Given this list of marker genes ECEL1, GTF2IRD2, SCN1A, ITGA7, TTN, PCYT1A, SPRTN, DKK1, PIGY, COL1A1, HSPG2, TFAP2A, HACD1, PSTPIP1, ERI1, SCUBE3, COMP, EIF4H (eukaryotic translation initiation factor 4H), LGI4, PPP1R12A, SCO2, FBXO28, GNPNAT1, WRN, KRT1, MYH3, IRF6, MVK, ERCC1, DDR2, ALOXE3 (arachidonate epidermal lipoxygenase 3), HFE, LMNA, GLB1, ACVR1, SCYL2, HRAS, MFN2, MASP1, COL25A1 (NCBI Gene Id 84570), LAMB2, WNT7A, ERCC8 (NCBI Gene Id 2075), SF3B4, MMP23B, SGSH, BAZ1B, SHH, LSS, FKBP10, ADGRG6, ACTA1, GABRG2, PRG4, TGDS, LBR, SMARCB1, TAF6, COL6A1, ADAMTSL2, PIEZO2, KCNAB2, PITX1, PCDH19, TBX4, GTF2I, SCN4A, GPC6, L1CAM, SCN9A, SCN1B, ALOX12B, CNTNAP1, RAD21, POMT1, BHLHA9, CAPN3, MMP13 (NCBI Gene Id 4322), MAF, SCARF2, RECQL4, NALCN, ERGIC1, ITCH, SLC22A4, TYROBP, PLOD1, UBA1, ELN, TREM2, VCP, MECP2, ALDH3A2, ALDH18A1, FGF9, PAX3, HOXA11, SFRP4, ESCO2, CHMP1A, STXBP1, KIF22, MET (MET proto-oncogene, receptor tyrosine kinase), COL1A2, NEK9, PYCR1, NFIX, NPR2, STAT4, ASXL1, GABRD, BANF1, B3GAT3, HGSNAT, MAN2B1, CCN6, IL10, RAB3GAP1, ACTB (NCBI Gene Id 60), RSPRY1 (ring finger and SPRY domain containing 1), GNS, SCN2A, FGFR2, SPRED2, GNB2, TRAPPC2 (trafficking protein particle complex subunit 2), FLNC, AGA (NCBI Gene Id 175), EMD, HCN1, CKAP2L, GPHN, SKI, TNFRSF11B, EMG1, LTBP2, TNNI2, TONSL, FGFR1, BMP6, SHOX, COL2A1, FILIP1, VAPB, TGFB1, IDUA, BMPR1B, HPGD, ZC4H2, PNKD, STAG1, GTF2IRD1, VANGL1, ANTXR2, EPG5, ADAMTSL4, DEAF1, MAP3K7, ARSB, PDPN, PSMB8, FGFR3, JAG2 (jagged canonical Notch ligand 2), CBS, INPPL1, GJB2, SYT2, GUSB, FUZ, ERCC2, ABCC9, FHL1, KCNK9 (potassium two pore domain channel subfamily K member 9), ROR2, IFITM5, STX1B, GLDN, FLNA, TBL2, PTPN2, PTF1A, RAB3GAP2, CCN2 (cellular communication network factor 2), LAMA2, LIFR, VPS33A, HDAC8, MED12, DYM, WFS1, PLOD3, CD96, OCRL, USB1, MAPK1, UNC80, COL6A3, ZNHIT3, ASAH1, MTX2, TPM3, TNNT1, EXT2, DYSF, SYNE2, MYBPC1, P4HTM, FKBP6, TRPV3, RMRP, CD247, ADGRV1, DVL1, TRPV4, FLII, FZD2, SMC1A, TBX3, GDAP1, ASPA, TBC1D20, FBN1, TMEM270, ATRX, IDH2, MBTPS2, CHST11, GNE (glucosamine (UDP-N-acetyl)-2-epimerase/N-acetylmannosamine kinase), ALG1, COL11A2, NIPA1, BRD4, CHST3, SLC26A2, OCA2, PTPN11, COL9A3, GNB1, GSC, NOG, RBMX, IDH1, RAB33B, SLC25A19, PKDCC, STX1A, PPP2R3C, HNRNPDL, CRLF1, SNRPB, TBX5, ERCC6, ACTG2, LEMD3, VPS37D, COL12A1, KRT83, KY, APC, AKT1, CLIP2, SMAD4, ERLIN2, SUZ12, PLOD2, OPA3, SPEN, MYH8, RSPO2, ADAMTS2, TDO2, GNAI3, PRDM16, SMAD6, B3GLCT, NIPBL, IL2RB, SLC6A5 (solute carrier family 6 member 5), SLC29A3, GPKOW, TOR1A (torsin family 1 member A), MAP3K20, MYL2 (myosin light chain 2), MYL1, ANKRD55, DST, FBN2, CTNNB1, P4HA2, TMEM43, NFKBIL1, PLP1 (NCBI Gene Id 5354), TBX15, SVIL, EXTL3, BPNT2, TGM1, CD244, ANO5, FGF13, FN1, ACTG1, MMP9, TNNT3, ZMPSTE24, BUD23, ADAT3, TMEM222, NOD2, SLC6A9, ADCY6, LUZP1, ANKH, PTPN22, STING1, LMBR1, CIITA, GNPTG, CLCF1, DNAJC30, RAI1, NOTCH3, SMC3, ADAMTS10, UBE3A, POR, RAB18, B3GALT6 (beta-1,3-galactosyltransferase 6), IL2RA, IDS, RERE, PIK3C2A, MUSK (NCBI Gene Id 4593), CASZ1, USP9X, HLA-DRB1, TPM2, EXT1, NDUFS3, LTBP3, SETBP1, LARGE1, GLE1 (GLE1 RNA export mediator), ATR, NAGLU, SYNE1, ENPP1, NSD1, GABRA1, GLRA1, GLRB, BGN, PLA2G6, MAFB, GNAS, GNPTAB, ASPN, PCNT, MACROH2A1 (NCBI Gene Id 9555), UBAP2L, GTPBP2, ATAD1 (NCBI Gene Id 84896), CPT2, CHRNG, SH3PXD2B (SH3 and PX domains 2B), HERC1 (NCBI Gene Id 8925), SGCA, SUMF1 (NCBI Gene Id 285362), NCF1, HLA-B, HS2ST1, F8, FLNB, WNT5A, BMP1, MYOT, GBE1, EZH2, ABCA12, COL6A2, SELENON, NDE1, UBE4B, SALL4, GDF5, RFC2, PERP, CISD2, ADAMTS17, RNU4ATAC, MATN3, MECOM, TFE3, COL27A1, LIMK1, PTH1R, ERCC5, DPYSL5, COLQ, PDGFRB, PHEX, PIGA, SLCO2A1, PRRT2, IQSEC2 (NCBI Gene Id 4382), DMD, COLEC11, COLEC10, ATP7A, PTDSS1, PRKCZ, HGD, LMX1B, SLC39A8, MMP2, CSGALNACT1, SLC25A46, TAF4, NAE1, METTL27, MYL11, FDFT1, here is a description of the gene set: Limitation of joint mobility Human Gene Set: HP_LIMITATION_OF_JOINT_MOBILITY A reduction in the freedom of movement of one or more joints. species: Homo sapiens